Given this list of marker genes ARHGAP31, EOGT, MT-TC, TBC1D24, FGFR1, ATP1A2 (NCBI Gene Id 93186), CRELD1, PRRT2, DNM1L, BAP1, MEFV, OPA1, HTRA1, CFHR1, NOTCH3, AKT1, PLA2G6, AGR2, HLA-DQB1, WDR62 (NCBI Gene Id 4181), FAS, TBX1, ENG, GNAQ, PRNP (NCBI Gene Id 96713), TSC1, MT-ND5, IL10, TSC2, C4A, TREX1, SMARCB1, MT-TQ, TRAF7, CCR1, UBAC2, ABCD1, ERAP1, HLA-B, AKT3, DCC, RBPJ, MT-ND6 (NCBI Gene Id 4541), TERT, HMGCL, MT-TL1, COL3A1, MT-ND4, CFH, MT-CYB, SLC1A3, SPOP, RHOBTB2, ADA2, IL12A, SCN1A, IFNGR1, HRAS, MT-CO2, ANO1, MT-TV, DLL4, AMACR, ANGPTL6, SLC2A1, MT-TW, MT-TK, TLR3, MT-TS2, MTHFR, TLR4, MT-TF, THSD1, SUFU, SP110, TGFBR3, GBE1, CACNA1A, TTR, MTOR, TBK1, AFG2B, ATP1A3, MT-ND1 (NCBI Gene Id 4535), KRAS, NF2, CYP26C1, SMARCE1, IL12A-AS1, COL4A1, STAT4, MT-CO3 (mitochondrially encoded cytochrome c oxidase III), GUCY1A1, MT-CO1, SMO, KLRC4 (NCBI Gene Id 8302), TPP2, TUBB2B, IL23R, NOTCH1, PDGFB, MT-TH, PRORP, DOCK6, PIK3CA, CFHR3, SMARCAL1, here is a description of the gene set: species: Homo sapiens Loss of strength in the arm, leg, and sometimes face on one side of the body. Hemiplegia refers to a complete loss of strength, whereas hemiparesis refers to an incomplete loss of strength. Hemiparesis Human Gene Set: HP_HEMIPARESIS